The following is a description of a gene set: Human Gene Set: GOBP_DNA_STRAND_ELONGATION species: Homo sapiens The DNA metabolic process in which an existing DNA strand is extended by activities including the addition of nucleotides to the 3' end of the strand., and this is the list of marker genes: NUCKS1, GINS1, PCNA, MCM3 (minichromosome maintenance complex component 3), INO80E, POLE3, YY1, DCLRE1B, MCM7, INO80D, RFC4, POLD2, RUVBL2, LIG3, MCRS1 (microspherule protein 1), MRE11, NBN, ACTR8, MCM4, LIG1, POT1, RUVBL1, RAD50 (NCBI Gene Id 10111), POLD3, NFRKB, INO80B, POLE, ACTR5 (NCBI Gene Id 93972), POLA1, INO80C, UCHL5, TFPT, DNA2, RFC3, TERT, ACTL6A, INO80